The following is a description of a gene set: Genes most significantly up-regulated in multiple myeloma samples, compared to normal bone marrow plasma cells. from publication Zhan F, Hardin J, Kordsmeier B, Bumm K, Zheng M, Tian E, Sanderson R, Yang Y, Wilson C, Zangari M, Anaissie E, Morris C, Muwalla F, van Rhee F, Fassas A, Crowley J, Tricot G, Barlogie B, Shaughnessy J Jr (PMID 11861292) studied in species Homo sapiens Human Gene Set: ZHAN_MULTIPLE_MYELOMA_UP Bone marrow plasma cells (PCs) from 74 patients with newly diagnosed multiple myeloma (MM), 5 with monoclonal gammopathy of undetermined significance (MGUS), and 31 healthy volunteers (normal PCs) were purified by CD138(+) selection. Gene expression of purified PCs and 7 MM cell lines were profiled using high-density oligonucleotide microarrays interrogating about genes. On hierarchical clustering analysis, normal and MM PCs were differentiated and 4 distinct subgroups of MM (MM1, MM2, MM3, and MM4) were identified. The expression pattern of MM1 was similar to normal PCs and MGUS, whereas MM4 was similar to MM cell lines. Clinical parameters linked to poor prognosis, abnormal karyotype (P =.002) and high serum beta(2)-microglobulin levels (P =.0005), were most prevalent in MM4. Also, genes involved in DNA metabolism and cell cycle control were overexpressed in a comparison of MM1 and MM4. In addition, using chi(2) and Wilcoxon rank sum tests, 120 novel candidate disease genes were identified that discriminate normal and malignant PCs (P <.0001); many are involved in adhesion, apoptosis, cell cycle, drug resistance, growth arrest, oncogenesis, signaling, and transcription. A total of genes, including FGFR3 and CCND1, exhibited highly elevated (spiked) expression in at least 4 of the 74 MM cases (range, 4-25 spikes). Elevated expression of these genes was caused by the translocation t(4;14)(p16;q32) or t(11;14)(q13;q32). Thus, novel candidate MM disease genes have been identified using gene expression profiling and this profiling has led to the development of a gene-based classification system for MM., and this is the list of marker genes: QSOX1, GART, SSRP1, EXTL2, ECH1, PFKM, ATF3, NKRF, CTSO, COX6B1, SMPD1, CD47, MASP1, FARSA, CASP1, LSR, COX17, SNHG14, MVP, ALG3, CARS1, RO60, PHB1, LAMC1, ZNF76, CAPN1, NAP1L4, PTPRK, UCHL1, NEB, H1-2, CDC34, MLLT3, CD200, TSC1 (NCBI Gene Id 7248), DNASE1L1 (NCBI Gene Id 1774), H2BC6, APC, NAA80, ILF3 (interleukin enhancer binding factor 3), ARID5A (AT-rich interaction domain 5A), FOXN3, EIF3B, MRPL58, H2BC21, PUM3, PTPA, USP4, EVI2A, SNX1, KAT2A (NCBI Gene Id 2648), HCP5, MAPKAPK3, BTF3P13, RBM10, PURA, ZNF136, MTA1, BCL7B, ABL1, DNMT1, CDKN1A, H2AC8, EWSR1